The following is a description of a gene set: species: Homo sapiens Genes down-regulated in ITGAM+ cells (incubated for 24h in complete medium) from spleen: healthy versus tumor bearing mice. from publication Gallina G, Dolcetti L, Serafini P, De Santo C, Marigo I, Colombo MP, Basso G, Brombacher F, Borrello I, Zanovello P, Bicciato S, Bronte V (PMID 17016559) Active suppression of tumor-specific T lymphocytes can limit the immune-surveillance and immunotherapy efficacy. While tumor-recruited CD11b+ myeloid cells are known mediators of tumor-associated immune dysfunction, the true nature of these suppressive cells and the fine biochemical pathways governing their immunosuppressive activity remain elusive. Here we describe a population of circulating CD11b+/IL-4Rα+, inflammatory-type monocytes that is elicited by growing tumors and activated by IFN-γ released from T lymphocytes. CD11b+/IL-4Rα+ cells produce IL-13 and IFN-γ and integrate the downstream signals of these cytokines to trigger the molecular pathways suppressing antigen-activated CD8+ T lymphocytes. Analogous immunosuppressive circuits are active in CD11b+ cells present within the tumor microenvironment. These suppressor cells challenge the current idea that tumor-conditioned immunosuppressive monocytes/macrophages are alternatively activated. Moreover, our data show how the inflammatory response elicited by tumors has detrimental effects on the adaptive immune system and suggest novel approaches for the treatment of tumorinduced immune dysfunctions. Human Gene Set: GSE5455_HEALTHY_VS_TUMOR_BEARING_MOUSE_SPLEEN_MONOCYTE_24H_INCUBATION_DN, and this is the list of marker genes: DYNLT3, PLXNC1, AXL, CNIH4, CD80, SLC22A15, KCNA3, TTC39B, MAP3K5, L3MBTL3, MYB, TRPS1, CAPG, ZC3H12A, MINDY3, ZBED5, NR2F6, IKZF2, KSR1, NKG7, ANKRD6, PON3, SLC12A2, FAM111A, RIPK3, NBN, TMEM38B, ADAM19, IL18, GFOD1, ARID5B, DERA, PLAAT5, INPPL1, IL21, DNAJC24, WNT10A, MAP3K8, ZNF518B, POLE3, ASAP1, RGL1, SLC24A3, PLAAT3, CHST11, FHL2, HECTD2, IFI27L2, ST3GAL1, LUZP1, ZNRF1, ARHGAP26, HMCES, TMBIM1, ABCB1, ELL2 (elongation factor for RNA polymerase II 2), KCNC2, SAMSN1, NANOS1, GABARAPL1, PRG3, BBLN, DUS2, EFHD2, MAPKAPK2, FAS, LSM6, PLSCR1, NUPR1, CARHSP1, ZC3H12D, MCM9, CASP1, S100A4 (S100 calcium binding protein A4), SLC41A1, EPGN, HGSNAT, MRPS6, PLAC8, WFIKKN2, BAIAP3, CD83, GATA3, CTLA4, B3GNT2, IL12RB1 (NCBI Gene Id 3594), GRAMD1B, PLEKHB2, STAC, TAF12, MPP2, LRIT1, ENDOD1, NDC80, ASPN, COMMD6, GLRX, TRPV1, DIPK2A, IRAK4, CD200, TOX2 (NCBI Gene Id 84969), NIBAN1 (NCBI Gene Id 63911), TUB, RAPH1, UBE2H, SLAMF6, SLA, ZC2HC1A, ZSCAN2, CXCL13, TAMALIN, SLC17A7, CD79B, PPP2R5C, DPP4, TNFRSF19, ARHGAP31, PRDM5, JARID2, VPS45, CDV3, LBH, STX11, MX2, PLCL1, SYPL1, ICOS, TNFRSF9 (TNF receptor superfamily member 9), SOX4, IL17RB (NCBI Gene Id 55540, interleukin 17 receptor B), WDR55, SAP30BP, PKP4, SYP, GFI1B, GALNT14, COBLL1, CKS2, ABTB3 (ankyrin repeat and BTB domain containing 3), EHD3, OAS1, BMP7, CASP4 (caspase 4), HAP1, RNF216, MAGED1, GRHL1, UBE2L3, PTPN3, IL1R1 (interleukin 1 receptor type 1), ACOT7, VSTM4 (NCBI Gene Id 196740), SCNN1G, CSK, POMP, EBNA1BP2, BATF, PDCD1LG2, IGLL1, RAB19, EVI5, CYFIP1, LCLAT1, CORO2B, POGLUT3, CACNA1D, GADD45B, CEP19, ADGRF1, GPM6B, LGMN, HOXB4, SYNGR2, RABEPK, DUSP4, HMGN3, LEO1, YBX3, ARMCX4, PHETA2, H2AZ1, RNF19B, BMP2K, RNF19A, ZC2HC1C, CYB561, SLC12A8, NRP1, TNFSF11, LRRC72, MRE11, MNS1, RNF149, FBXO4, ACOT2, STK39, IGLC7